Given this list of marker genes SCN7A, EPHB2, PAK1, SCN10A, SCN2B, TUBA1A, EZR, NUMB, ITGB1, TUBA3E, SPTA1, TUBB4B, ITGA2B, LAMC1, SPTBN4 (NCBI Gene Id 80322), SRC, TUBB2B, GAP43, SCN3A, MAPK3, AP2M1, AP2A1, LYPLA2, RPS6KA2, CNTN6, RAC1, KIF4B, TUBB4A, SCN2A, ITGB3, LAMB1, ITGAV, TUBA4A, DCX, RANBP9, KCNQ2, RPS6KA1, ITGA10, TUBA1B, DPYSL2, NRP1, TUBB8B, SPTB, DNM2, ITGA9, KIF4A, AP2B1, TUBB1, TUBA3C, SCN4B, NRP2, SHTN1, ITGA5, CD24, NFASC, SPTBN2, SPTBN5, TUBB8, SCN3B, ACTB, CNTN2, SCN5A, RDX, SDCBP, ITGA2, SCN1A, CSNK2A2, ITGA1, FGFR1, CLTC, CNTN1, DLG4, DNM1, DLG3, HSPA8, SPTAN1, TUBB6, AP2S1, NCAM1, SCN9A, DLG1, NRCAM, TUBA1C, RPS6KA6, SCN1B, TUBB2A, TUBA8, CSNK2A1, NCAN, AP2A2, SPTBN1, LAMA1, TUBB3, ANK2, TUBA4B, ANK1, MAP2K2, MAPK1, RPS6KA3, L1CAM, KCNQ3 (NCBI Gene Id 3786), ACTG1, DNM3, CNTNAP1 (contactin associated protein 1), EGFR, TUBA3D, SH3GL2, RPS6KA5, VAV2, ALCAM, CHL1, MSN, SCN11A, SCN4A (NCBI Gene Id 6329), TUBAL3, MAP2K1, CLTA, ANK3, SCN8A (NCBI Gene Id 6334), CSNK2B, RPS6KA4, here is a description of the gene set: studied in species Homo sapiens The L1 family of cell adhesion molecules (L1CAMs) are a subfamily of the immunoglobulin superfamily of transmembrane receptors, comprised of four structurally related proteins: L1, Close Homolog of L1 (CHL1), NrCAM, and Neurofascin. These CAMs contain six Ig like domains, five or six fibronectin like repeats, a transmembrane region and a cytoplasmic domain. The L1CAM family has been implicated in processes integral to nervous system development, including neurite outgrowth, neurite fasciculation and inter neuronal adhesion.<br>L1CAM members are predominately expressed by neuronal, as well as some nonneuronal cells, during development. Except CHL1 all the other members of L1 family contain an alternatively spliced 12-nclueotide exon, encoding the amino acid residues RSLE in the neuronal splice forms but missing in the non-neuronal cells. The extracellular regions of L1CAM members are divergent and differ in their abilities to interact with extracellular, heterophilic ligands. The L1 ligands include other Ig-domain CAMs (such as NCAM, TAG-1/axonin and F11), proteoglycans type molecules (neurocan), beta1 integrins, and extra cellular matrix protein laminin, Neuropilin-1, FGF and EGF receptors. Some of these L1-interacting proteins also bind to other L1CAM members. For example TAG-1/axonin interact with L1 and NrCAM; L1, neurofascin and CHL1 binds to contactin family members. The cytoplasmic domains of L1CAM members are most highly conserved. Nevertheless, they have different cytoplasmic binding partners, and even those with similar binding partners may be involved in different signaling complexes and mechanisms. The most conserved feature of L1CAMs is their ability to interact with the actin cytoskeletal adapter protein ankyrin. The cytoplasmic ankyrin-binding domain, exhibits the highest degree of amino acid conservation throughout the L1 family. part of: Axon guidance Reactome Pathway: L1CAM interactions